Given this list of marker genes ABCC6, LBR, ANKH, TNFRSF11B, ENPP1, DDR2, PEX5, SLC26A2, MGP, ZBTB20, PEX2, HGD, here is a description of the gene set: Calcification of cartilage The presence of calcium deposition in cartilage. species: Homo sapiens Human Gene Set: HP_CALCIFICATION_OF_CARTILAGE